The following is a description of a gene set: from publication Lund R, Aittokallio T, Nevalainen O, Lahesmaa R (PMID 14607935) Genes down-regulated in CD4 T cells activated by anti-CD3 and anti-CD28: IL-12 (48h) versus IL4 (48h). Th1 and Th2 cells arise from a common precursor cell in response to triggering through the TCR and cytokine receptors for IL-12 or IL-4. This leads to activation of complex signaling pathways, which are not known in detail. Disturbances in the balance between type 1 and type 2 responses can lead to certain immune-mediated diseases. Thus, it is important to understand how Th1 and Th2 cells are generated. To clarify the mechanisms as to how IL-12 and IL-4 induce Th1 and Th2 differentiation and how TGF-beta can inhibit this process, we have used oligonucleotide arrays to examine the early polarization of Th1 and Th2 cells in the presence and absence of TGF-beta after 0, 2, 6 and 48 hours of polarization. species: Homo sapiens Human Gene Set: GSE2770_IL12_VS_IL4_TREATED_ACT_CD4_TCELL_48H_DN, and this is the list of marker genes: NFATC3, SETD1A, KRTCAP3, RUFY3, EZR, HEXIM1, LY9, RPS9, CUL2, B3GNT8, SYNJ2, TRUB1, SLC2A9, SORBS1, CAB39L, IQCE, STX17, SLC4A8, STARD4, RAP1GDS1, DGLUCY, INVS, DNAAF9, CYP4V2, REV3L, TBC1D14, MAPK11, ARHGAP8, ZC3H7B, BLTP1, SBNO1, DUS2, APPL2, CDK10, ZC3H12A, HSD17B7, PLEKHO1, RELCH, LAMB3, MED13L, MAP2K5, NUBPL, FAU, LCK, TCF4, SIGIRR, KRAS, NAB2, DAZAP2, METAP1D, RIPK2, FMO5, KDM2B, KMT2A, APBB1IP, CYFIP1, NFATC2, KCNG1, STARD10, ASB2, ZBTB37, PAWR, ZNF346, TMEM14A, ETFRF1, SRGAP3, CD2, SEC22C, ENTPD5, HLA-DRA, CDH17, TERB1, LRRC42, PPM1L, RFTN2, RDH12, HSPA4, CABLES2, CHD6, MACIR, MGA, CAPRIN2, APOE, ZFP69, ZNF579, ZFP28, TEX9, CYB561A3, DIPK1A, ZBTB32, RUSF1, LYNX1, RALGAPB, KIF2A, PPCDC, DEXI, COPG2, WDR41, NCKIPSD, KIAA0753, CMTR1, TMEM229B (transmembrane protein 229B), NCOA3, CFAP96, MICU3, MECP2, C19orf48P, CD86, TMEM209, CDON, SETX, ARHGAP35 (NCBI Gene Id 79266), BATF, CHST11, PVT1, GNG10, ANKRD16, PCIF1, TMEFF1, CD300LF, SS18, TENT4B, EPC1 (enhancer of polycomb homolog 1), ITPR3, AHCTF1 (NCBI Gene Id 442770), TTYH2, PLEC, CD2AP, AP1M2 (adaptor related protein complex 1 subunit mu 2), E2F5, SLC2A4RG, SLC9A5, AKAP7, RETREG3, GCNT1, AFF4, ARL4A (NCBI Gene Id 10124), ARRB1, VPS33A, HSDL2, TMX4, SCAF8, SAMD1, TSPAN32, ASAP1, TET3 (NCBI Gene Id 23298), PLPP3, GIMAP4, MLLT6, DTNBP1, PRKAB2, LNX2, TCEA2, FLYWCH1, FCHSD1, UBXN11, IL2RB, BORCS6, HEATR6, HIF1A, DUSP2, NSMCE1, GTF2I, ICE2, MEST, TESK2, RPS6KA3, DIAPH2, CORO1B, PXK, TNFAIP8L2, UNC119B (unc-119 lipid binding chaperone B), ENOX2, TRAF3 (TNF receptor associated factor 3), BLOC1S5, EGLN2, RAB11FIP4, TPK1, SAV1, RAP1B, ZC3H12C, ANGPTL1, ZBTB10, USP4, LFNG, BRAT1, DDB2, C5orf34, ARFRP1, ATP10D, SBF2, PITPNM2, FOSL2, UBXN2A, ZNF398, ERLIN1, SMURF1, IRF5, AP1G2